The following is a description of a gene set: Human Gene Set: TONKS_TARGETS_OF_RUNX1_RUNX1T1_FUSION_MONOCYTE_UP from publication Tonks A, Pearn L, Musson M, Gilkes A, Mills KI, Burnett AK, Darley RL (PMID 17898786) Genes up-regulated in monocytes by RUNX1-RUNX1T1 fusion. The t(8;21)(q22;q22) occurs frequently in acute myelogenous leukaemia and gives rise to the transcription factor fusion protein, RUNX1-RUNX1T1 (also known as AML1-ETO). To identify the genes dysregulated by the aberrant transcriptional activity of RUNX1-RUNX1T1, we used microarrays to determine the effect of this mutation on gene expression in human progenitor cells and during subsequent development. Gene signatures of these developmental subsets were very dissimilar indicating that effects of RUNX1-RUNX1T1 are highly context dependent. We focused on gene changes associated with the granulocytic lineage and identified a clinically relevant subset of these by comparison with 235 leukaemia patient transcriptional signatures. We confirmed the overexpression of a number of significant genes (Sox4, IL-17BR, CD200 and gamma-catenin). Further, we show that overexpression of CD200 and gamma-catenin is also associated with the inv(16) abnormality which like RUNX1-RUNX1T1 disrupts core binding factor activity. We investigated the functional significance of CD200 and gamma-catenin overexpression in normal human progenitor cells. The effect of IL17 on growth was also assessed. Individually, none of these changes were sufficient to recapitulate the effects of RUNX1-RUNX1T1 on normal development. These data provide the most comprehensive and pertinent assessment of the effect of RUNX1-RUNX1T1 on gene expression and demonstrate the highly context-dependent effects of this fusion gene. species: Homo sapiens, and this is the list of marker genes: RRP9, TUBB2A, TP53I3, TNPO2, CD180, MYOF, PES1, SOX4, DHRS9, PLIN2, SLIRP, DUSP6, FJX1 (NCBI Gene Id 24147), EXT1, EBNA1BP2, TUBB6, MMP10, RAB13, PDGFA, COL1A2, ISG15, CENPX, DKC1, ST6GAL1, MMP1 (NCBI Gene Id 4312), ALDH1A2, KHSRP, MT1H, NOP56, SNRPA1, PPP1R14B, QPRT, TFPI2 (tissue factor pathway inhibitor 2), MDH2, ZFTA, MRPS35, RAD54L2, FASTKD1, TFPI, WDR43 (WD repeat domain 43), MYBBP1A, DDX18, LPL, CBS, LIMS1, SFXN1, UNG, NHP2, OAS1, PLPP3, FARP1, HPGDS, UXS1, NEFH, HSPE1, PSMD12, TM4SF1, MRPL17, PLS3, ESF1, PWP1, CH25H, GLRX3, CAVIN1, CTDSPL, L1CAM, C1QBP, NR2F6, GFOD1, ADAP2, MREG, G0S2, TCP1, TEX2, TNNT1, SASH1, DDX24, SPATS2L, BZW2, SLC16A1, CCL8, PTDSS2, CCND2, GPS2, CYP1A1, KANK2, SLC39A7, GCSH, GTPBP4, ARHGEF12, NCLN, NES, TCF7L2, EIF3B, USP18, MT2A, GBP1, TRIP6, ICAM2, INHBA, APLP2, IFIT1, OLR1, HSPD1, ECI2, DAG1, DLAT, PLTP, SEH1L, IFI44L, HERC5 (HECT and RLD domain containing E3 ubiquitin protein ligase 5), GPR20, SLC20A1, ARG2, TRMU, SPTAN1, GOSR2, RHOBTB1 (Rho related BTB domain containing 1), APOE, HSPB1, PPME1, ATP1B3, FABP3, PUS1, PA2G4, FAM136A, UBA5, CRHBP (NCBI Gene Id 1393), NME1, BCL2A1, PPFIBP1, NDUFAB1, LGALS9, AKR1C3, MYRF, FAM216A, SLCO4A1, LY6E, ANKRD40, TBXA2R, MX1, MTX1, CSF1, RGCC, CXCL10, CKB, EIF4EBP1, LAPTM4B, AQP1, HGF, IFI44, FLNB, CDC123, GDF15, SELENOP, POLE2, NOLC1, FGFR1 (NCBI Gene Id 84151), TMEM158 (NCBI Gene Id 25907), DEXI, ATP5ME, SIVA1, PXDN, GSPT1, MT1X, SLC5A3, AK2, DNAAF2, HOMER1, GATAD2A, SLC9A1, TRIP13, EPS8, SMARCA4, ECHS1, EPRS1, KCNN4, TRIB3 (tribbles pseudokinase 3), UCHL1, FERMT2, TREM1, PFKP, CALU, NAP1L1, ARL4A (ADP ribosylation factor like GTPase 4A), PFKM, HSPA5, NPM1, UBE2J1, CTPS1, PSMB5, ARAP3, DUSP14, JAM3, HOMER3, IFRD2, AMPD2, SORD, TNPO1, EHD2, NOP14, RMND5A, DDR1